Given this list of marker genes FBXW7, USP9X (ubiquitin specific peptidase 9 X-linked), VPS13C, TIMM23B, TOMM20L, STAM, POLA2, GOLPH3L, TCP1, TIMM13, CBLB, PRICKLE1, LAMP2, LEPROT, SEC61A2, PPP3R1, JUP, RN7SL1, RGPD3, MAN1A1, SH3GLB1, MVB12B, VPS25, SUMO1, IFNG, YWHAB, IPO4, TIMM17B, SIRT6 (NCBI Gene Id 51548), VPS37D, TNPO3, GJD2-DT, E2F3, LONP2, SNF8, VPS37B, AP3B1, VPS13D, SIRT4 (NCBI Gene Id 23409), TERF1, PEX26, STK4, ZNF827, UBE2J2, STAM2, ECT2, NUP88, NUP85, TRAM1, ATG14, DDIT3, CALM3, PIK3R2, MAPK8, TOMM34 (NCBI Gene Id 95099), VPS11, CD36 (CD36 molecule (CD36 blood group)), TRAM2, RAB3GAP2, ADAR, APPL1, FAM53B, ZFAND2B, TARDBP, TIMM10, TMCO6, SEC61A1, GGA3, GCKR, ANKRD10, EDEM1, HSPD1, LMAN1, IMMP2L, TSPO, PIK3R1, SORT1 (NCBI Gene Id 6272), SRP19 (signal recognition particle 19), PRKD1, XBP1, OXA1L, GOLPH3, CRY2, CTCFL, SYK, TXNIP, APOD (apolipoprotein D), RN7SL2, NABP2, LRWD1, NUP50, RGPD6, BAX, FGF9, USP7, NFKBIA, AP4M1, NF1, RBM22, LAMP3, GFER, RGPD5, HERPUD1, MBTPS1, SRP72, KPNA4, CHCHD4, RPAIN, LRRK2, POM121, CSNK2A2, SSR3, UBE2D3, DNAJA1, BAG4, LRSAM1, NUP54, TMEM126A, ZPR1, EFCAB7, RAB3GAP1, NPM1, RAN, CHP2, BCAP31, EPS15, MACROH2A1, SHH (sonic hedgehog signaling molecule), HSPA5, NUP107, M6PR, BRCA2, WASH3P, MTX2, MED1, KPNA6, ING1, IPO7, MACROH2A2, MFF, TIMM29, GET1, SEC63, TPR, SEC61B, SGTA, SEC62, POM121B, PIK3C3, TRIM28, MMP12, LAMP1, GRPEL2, SPG11 (NCBI Gene Id 80208), EPM2A, AP3M1, RUVBL2, IPO13, TRAM1L1, SPIDR, MAPT, LAPTM5, TIMM8A, TERT, VPS4A, NEURL1B, VPS13A, IPO11, NPAP1, AKIRIN2, SMURF1, SRP68, MOAP1, SEC13, HUWE1, RYR2, UFM1, VPS37C, TOMM5, RAB7A, DMAP1, TOMM70, NUP58, RAB8B, VPS28, SAMM50, TIMM10B, TIMM22, PMPCB, DNLZ, NDP, PPP3CA, HSP90AA1, GDAP1, LAMP5, NUP214, VPS37A, TOMM40, PAM16, SIX3, ZFAND6, AIP, CDK1, NCOA4, UBR5, PEX7, SPDYA, MAVS, GZMB, PEX19, HYAL2, DNAJC15, HGS, TTC9-DT, SPCS2, C11orf65, PTPN23, MGARP, POT1, PML, MAIP1, SUFU, TRAF3IP2, MTCH1, SRP9, WBP2, VPS36, RALA, TGFB1, APPL2, PKIG, HDAC3, MON1B, NUP35, RAB11A, UBL5, KPNA2, MVB12A, HEATR3, IFT122, GLP1R, MON1A, POM121C, RGPD4, CHMP4B, BHLHE40-AS1, NUTF2, PEX12, ATF2, TOMM40L, SRP14, TOMM20, TSC2, SORL1, HSPA4, VPS8, NUP188, PINK1, IRGM, TIMM17A, MTX1, TNPO1, LMNA, KPNB1, SREBF2 (NCBI Gene Id 6721), CHP1, CSE1L, CD68, RPL23, VPS54, SGTB, MTERF4, TSG101, PIK3R4, SRPRA (SRP receptor subunit alpha), ABRA (NCBI Gene Id 137735), NDUFA13, ELAVL1 (NCBI Gene Id 1994), PIN1, UBL4B, BCS1L, KCNQ3, ATG13, TIMM23, HAX1 (HCLS1 associated protein X-1), SEC61G, BAG6, AKT1, JAK2, HCLS1, TIMM44, ZFAND2A, PPP1R10, HTRA2 (NCBI Gene Id 27429), STAT3, PRKN, H1-5, BAP1, BCL3, TOMM6, RAB23, ANGPT1, ABLIM3, UBAP1 (ubiquitin associated protein 1), CLU, IPO8, SREBF1, AP3D1, PRKCD, GRPEL1, NUP155 (NCBI Gene Id 9631), FAM53C, RANBP17, IMMP1L, KPNA5, ROMO1, HPS4, SAE1, PEX16, FZD5, NEURL3, RHOU, RNF31, EIF4ENIF1, NUP133, HIKESHI, MTCH2, DRD1, SNAP25-AS1, PEX5L, NOTCH1, NMT1, NIPBL, TIMM21, BECN1, LEP, BMP4, RGPD8, SQSTM1, ENSG00000283175 (novel transcript, antisense to MASP1), FIS1, SNUPN, ANKRD6, STK3, EI24, PSEN1 (NCBI Gene Id 5663), HSPA8, PRKAA1, RAB10, ZC3H12A, SPRN, UBL4A, SIX2, ZIC1, MICALL2, TRMT10B, NPEPPS, UBE2L3, CDKN1A, GLI3, IL33, CDKN2A, HK1, PEX6 (NCBI Gene Id 5190), PKIA, ADCY10, NUP62, ARIH2, ZDHHC15, EP300, COX18, GCC2, PEX5, TIMM50, PEX1, IPO5, BAG3, RGPD1, SMAD3, VPS53, TSPAN10, HSPA1L, SIAH3, GET4, GNPTAB, TNFAIP3, HK2, FERMT1, FBXO7, MIPEP (NCBI Gene Id 4285), PEX2, POM121L2, SRP54, PEX10, GNPTG, SGF29, BNIP3L, CCT6A, RGPD2, NUP98, PEX3, NAGPA, CABP1, ATP5IF1, PHB2, PMPCA (NCBI Gene Id 23203), MAPK14, NRARP, CWH43, BBC3, SPCS3, CFL1, TOMM7, TIMM8B, GSK3A, PARL (NCBI Gene Id 55486), TNPO2, TP53, BID, TOMM22, RN7SL3, WRAP53, DNAJC19, KPNA3, RAC2, IL10RA, CHMP4A, MFN2, AGK (acylglycerol kinase), HACL1, PITRM1, RANBP2 (RAN binding protein 2), NUP153, SMO, KPNA1, IPO9, NUP93, PTTG1IP, VPS41, SNX16, NEDD4, FLNA, ACD, SCARB2, MDFIC, PEX14, TSPAN17, CDH1, KPNA7, SRPRB, CBL, RANBP6, ZFYVE16, NR4A1, SPCS1, PEX13, TRIM37, USP36 (ubiquitin specific peptidase 36), FAM53A, AIFM1, TIMM9, here is a description of the gene set: species: Homo sapiens The directed movement of a protein to a specific location on or in an organelle. Encompasses establishment of localization in the membrane or lumen of a membrane-bounded organelle. Human Gene Set: GOBP_ESTABLISHMENT_OF_PROTEIN_LOCALIZATION_TO_ORGANELLE